The following is a description of a gene set: Human Gene Set: HP_RETINAL_VASCULAR_TORTUOSITY Retinal vascular tortuosity The presence of an increased number of twists and turns of the retinal blood vessels. studied in species Homo sapiens, and this is the list of marker genes: CENPF, BAZ1B, STX1A, MT-CYB, LAMB2, SEC24C, MT-ATP6, DNAJC30, GP1BB (NCBI Gene Id 89199), HIRA, MT-ND4L, SELENOI, GTF2IRD1, DGCR6, DGCR8, GTF2I, UFD1, METTL27, NCF1, MT-ND2, COMT, TMEM270, FKBP6, RREB1, ANTXR1, TBL2, ELN, ARVCF, WT1, MT-ND1, CLIP2, LIMK1, ETHE1, LRP5, MLXIPL, NEK1, NDUFS2, FZD4, BUD23, NDP (norrin cystine knot growth factor NDP), DGCR2, EIF4H, MT-CO3, ESAM, MT-ND5, MT-ND6, MT-CO1, MT-ND4, PAX6, RFC2, JMJD1C, IFT172, COL4A1, TBX1, GTF2IRD2, ESS2, VPS37D